The following is a description of a gene set: studied in species Homo sapiens Human Gene Set: GOCC_OLIGOSACCHARYLTRANSFERASE_COMPLEX A protein complex that is found in the endoplasmic reticulum membrane of eukaryotes and transfers lipid-linked oligosaccharide precursor to asparagine residues on nascent proteins. The complex includes at least eight non-identical subunits. Different forms of the complex containing distinct subunits have been detected in mammals., and this is the list of marker genes: OST4, TUSC3, DDOST, RPN1, KRTCAP2, STT3B, TREX1, OSTC, DAD1, MLEC, MAGT1, RPN2, TMEM258, STT3A